Given this list of marker genes ADGRV1, OTUD3, BAG1, TMEM88, NDC80, APOA1, MFSD1, NAA16, IFT46, TPR, USP48, TYROBP, UFL1, USP40, MYLIP (NCBI Gene Id 29116), DVL1, CRTAP, SH3GLB1, MYCNOS, AFM, TAF1, USP17L8, ISOC2, BBOF1, CTSA, PFDN2, BAG2, HSP90AB2P, CDC37L1, USP17L12, CAPN3, DDOST, IGF1, POLR2E, SAXO1, TRIM39, SIRT1, SIRT6, CPN2, COG7, SMAD7, TBRG1, PHB2, IP6K2, DCAF11, USP17L6P, IRGM, URI1, CRYAB, PYHIN1, TCP1, STXBP4, NCLN, TREX1, NAA30, MUL1, DAZAP2, FLNA, MORC3, PPP1CA, PDCD10, USP17L3, TESC, USP24, NPM1, PPARGC1A, ATP1B3, USP38, CCAR2, ASDURF, LAMP1, PARK7, HAPSTR2, CCT8, USP17L1, TARDBP, RNF149, UTP25, QRSL1, UBE2B, BAG6, FAM107A, USP17L17, USP28, USP17L5, HIP1, PRKDC, TADA3, TP53, HSP90AA2P (NCBI Gene Id 650589), USP5, FBXO7, SUMO1, SYVN1, NEDD4L, CEP63, CLU, PLK1, NAPG, ATP1B1, KDF1, USP2, DAD1, RPL23, DACT1, HSPA1B, CDKN2AIP, FBXW11, RTN4, MTMR1, P3H1, RASSF1, USP13, PDCL3, CUL3, NCKAP1, COG3, SERF1A, LMNA, GOLGA7, PEX2, PFDN6, BAG4, USP17L19, TAF9B, RAD23A, FBXW7, IAPP, HTT (huntingtin), USP47, GET4, TMC6, USP17L20, HPS4, SIAH1, USP7, DSG1, MTMR9, RNF139, PPP1R10, USP1, USP33, INSC, IFI30, GET1, USP36, RNF128, PER3, UXT, SEL1L, APTX, USP26, DSG3, AURKA, BTRC, PINX1, FLOT1, HSP90AB1, RNF5, CREBBP, KDM8, PYURF, C10orf90, CD81, CMTM6, DDI2, STUB1, ID1, XBP1, MCM8, YWHAZ, USP35, A1CF, USP17L21, RUVBL2, RABL3, CBLC, USP27X, PEX19, HDAC3, SERF2, COA8, USP8, DDRGK1, USP10, WFS1, LRRK2, GRN, CCT2, TERT, EFNA1, USP17L24, USP34, CD74, SERF1B, UBR4, NR1D1, GNAQ, GGA3, CDC37, USP17L22, HIP1R, TMC8, ATP1B2, USP17L18, SIAH3, BAG3, CCT7, TTI2, UBL4A, PTEN, CHP1, USP29, SOX4, SMAD3 (NCBI Gene Id 51521), SAV1, HSPD1, PIM2, WDR81, CTSH, AHSP, PRKN, ZBED3, CHFR, RASSF2, SEC16A, HSPA1A, ASPH, KHDRBS1, WIZ, PLPP3, GSN, TBL1X, SPPL2C (signal peptide peptidase like 2C), STX12, CDC73, TSC1, CCT5, H1-5, USP17L4, MSX1, ABTB3, PRKRA, USP17L7, FLOT2, PPIB, HDAC6, GAPDH, PARVA, TTI1, RUVBL1, TF, MFSD8, PFN1, BCL2, SRC, CCDC88C, AHSA1, IFT80, SENP2, USP25, TSPAN1, SLC51B, BMP2, SNCA, KAT2A, USP30, USP42, SEPTIN8, NAA15, USP37, ZSWIM7, TRIM44, PEX6, NLK, CDKN2A, HCFC1, GTPBP4, GPIHBP1, HYPK, CCT3 (chaperonin containing TCP1 subunit 3), PINK1, HSP90AA1, MTOR, CHEK2, TELO2, SOX17, MDM4 (NCBI Gene Id 4194), EPHA4, MDM2 (MDM2 proto-oncogene), DDI1, GIPC1, USP17L11, CRYAA, CSN3, PRNP, RPAP3, LSS, STXBP1, BAG5, NF2, TNIP2, USP9Y, USP18, CREBL2, USP17L2, MAPK1, CTNND1, CSNK2A1, PML, USP17L15, PHB1, GBA3, LAMP2, RPL5, GNL3L, CAMLG, TMEM25, DNAAF10, PDRG1, TBX3, HSP90AB3P, USP17L10, HSP90AB4P, USP4, HSPA8, SREBF1, VPS11, GLMP, ANK2, PTGES3 (NCBI Gene Id 10728), PAQR4, FBXO4, USP46, DNLZ, ZNF207, RAB21, SUGT1, MIR101-1, SWSAP1, VPS35 (VPS35 retromer complex component), PIN1, USP12, FBXL3, CCNH, SMO, TRIM21, HDAC8, STK4, RPS7, DSC3, STK3, B4GALT5, APOA2, RPL11, CREB1, VHL, PIM1, MARCHF7, DERL1, AKT2, COMMD1, DNAAF2, DNAJA3, MOSMO (NCBI Gene Id 730593), TAF9, CDK7, BRINP1, TOMM7, KLF1, USP9X, PANO1, PYCARD, NOP53, CCT6A, AAK1, PRKCD, PIH1D1, MT3, USP19, PFN2, PIK3R1, DVL3, PIH1D2, TRIM37, WNT10B, FREY1, CCT4, TRIM24, SPAG1, HOXB-AS3, USP17L13, MAPK8IP3, CASP3, CALR, EP300, here is a description of the gene set: species: Homo sapiens Any process that affects the structure and integrity of a protein, altering the likelihood of its degradation or aggregation. Human Gene Set: GOBP_REGULATION_OF_PROTEIN_STABILITY